Given this list of marker genes Aqp1, Cyb5r2, Cyb5rl, Slc4a1, Hbb-bt, Car2, Car1, Rhag, Hba-a1, Hbb-bs, Cyb5r1, Cyb5r4, Car4, here is a description of the gene set: studied in species Mus musculus Erythrocytes take up carbon dioxide and release oxygen Mouse Gene Set: REACTOME_ERYTHROCYTES_TAKE_UP_CARBON_DIOXIDE_AND_RELEASE_OXYGEN